Given this list of marker genes TOE1, CNOT6L, PDE12, NOCT, CNOT1, PARN, PAN3, CNOT7, CNOT2, PNLDC1, CNOT6, PAN2, CNOT8, here is a description of the gene set: Catalysis of the exonucleolytic cleavage of poly(A) to 5'-AMP. studied in species Homo sapiens Human Gene Set: GOMF_POLY_A_SPECIFIC_RIBONUCLEASE_ACTIVITY